The following is a description of a gene set: Bipolar disorder is an illness of mood characterized by alternating episodes of elevated and depressed moods, which are interspersed with euthymic periods. Bipolar affective disorder Human Gene Set: HP_BIPOLAR_AFFECTIVE_DISORDER studied in species Homo sapiens, and this is the list of marker genes: ATP2A2, HIRA, GRIA1, POLG (NCBI Gene Id 5428), CHRNA7, FA2H, MT-ND1, MT-CO1, PDGFRB, MT-TF, DNMT3A, MT-ND5, JMJD1C, GP1BB, RNU4-2, EHMT1, VPS16, MT-CO2, MT-ND6, RPS6KA3, MT-TS2, MT-CO3, UFD1, TBX1, MT-TQ (NCBI Gene Id 4572), RREB1, MT-TL1, POLG2, RBM12, FLI1, SEC24C, TBCK, MT-TW, MT-ND4, ARVCF, SMPD1, SLC25A4, MT-TH, MECP2, CEP85L, COMT, CLCN4, TWNK, RRM2B